Given this list of marker genes H3c6, Psma2, Mtbp, H3c8, H2ac23, H4c4, H2ac22 (NCBI Gene Id 319170), Dnm2, H2ac13, H3c4, H2ax, Spcs1, Psmb4, Psma6, Tyrobp, Ctss, H4c8, Cdh5, H4c1, Prkcsh, Ezh2, H2ac1, H3c2 (NCBI Gene Id 319150), Psmd6, Cdh15, Rack1, H2bc27, Nectin2, Psmb5, H2ac12, Ilk, Banp, H2ac20, Dad1, Kdm1a, H2bc9, Psma1, H4c12, H2bc22, Sdk1, Pip5k1c, Pomt2, H2bc1, H2bc11, Angptl4, Ubb, H4c18, Pcsk7, Fyn, Smarca4, Sec11c, Zmym2, Twist1 (NCBI Gene Id 22160), Ang, Cdh8, H2bc3, Rbbp4, Pxn, H3c15, Psmd12, H2az2, Rbbp7, Col17a1, Il6, Grb2, Krt14, H2ac10, H3c1, H3c13, Fblim1, H2ac7 (H2A clustered histone 7), H2ac24, Spcs3, Psmc5, Psmc6, H3c10, Cdh3, Ctnnb1, Actg2, Cadm3, Lims2, Vasp, Csnk2b, H2bc8, H4c2, Psma4, Cdh6, H4c3, Cdh1, Psmd1, Pard3, H2ac15, Nphs1, Spcs2 (NCBI Gene Id 66624), Psmc3, Fermt2, H2ac19, Psma7 (NCBI Gene Id 26444), Stt3a, H4c17, Psmb7, Ilf3, H4c6, Tesk1, Psmb6, H2ac8, H2bc12, H2bc13, Cdh2, Jup, Psma5, H2bc7, Flnc, Cd151, Ganab, Nfkb1, Cdc42, H3c3, Tmem258, Rps27a, Ddost, Dnttip1, Psmc1, Cdh18, Tyk2, Sftpd, Psma3, H2ac6, H4c9, Psmd7 (NCBI Gene Id 17463), Pard6g, Il6ra, Acta1, H2ac4, Psmc4, Rela, H4c14, Psmd13, Kirrel2 (NCBI Gene Id 243911), H3c7, Actc1, Psmc2 (proteasome (prosome, macropain) 26S subunit, ATPase 2), H3f3a, Cdh12, Nectin4, Cdh7, Ost4 (oligosaccharyltransferase complex subunit 4 (non-catalytic)), Pomt1, H4c11 (NCBI Gene Id 319159), H2bc15, Cbll1, Adam19, H3c11, H2ac11, here is a description of the gene set: studied in species Mus musculus This event has been computationally inferred from an event that has been demonstrated in another species.<p>The inference is based on the homology mapping from PANTHER. Briefly, reactions for which all involved PhysicalEntities (in input, output and catalyst) have a mapped orthologue/paralogue (for complexes at least 75% of components must have a mapping) are inferred to the other species. electronically inferred by orthology from the curated human pathway Reactome Pathway: Cell-Cell communication